Given this list of marker genes ELAVL4, LINC00511, LINC00486, RPL12, RNVU1-28, LINC00477 (long intergenic non-protein coding RNA 477), SNORD118, NEAT1 (NCBI Gene Id 283131), IL2RA, DDIT3, ATP6V0D1, SNORD13, MBD6, TTI2, SNORD3A, DDX18P5, RNVU1-14, ZFAND3, LRSAM1, MPND, ENSG00000229664, RNVU1-15, RNU4-2 (NCBI Gene Id 26836, RNA, U4 small nuclear 2), here is a description of the gene set: Genes containing one or more binding sites for (SVIL) in their promoter regions (TSS -1000,+100 bp) as identified by GTRD version 20.06 ChIP-seq harmonization. Human Gene Set: SVIL_TARGET_GENES from publication Yevshin I, Sharipov R, Kolmykov S, Kondrakhin Y, Kolpakov F (PMID 30445619) species: Homo sapiens